The following is a description of a gene set: Human Gene Set: GSE30962_PRIMARY_VS_SECONDARY_CHRONIC_LCMV_INF_CD8_TCELL_UP species: Homo sapiens Genes up-regulated in comparison of splenic primary CD8 effector T cells at day 8 post-chronic infection versus splenic secondary CD8 effector T cells at day 8 post-chronic infection. Understanding the response of memory CD8 T cells to persistent antigen re-stimulation and the role of CD4 T cell help is critical to the design of successful vaccines for chronic diseases. However, studies comparing the protective abilities and qualities of memory and naïve cells have been mostly performed in acute infections, and little is known about their roles during chronic infections. Herein, we show that memory cells dominate over naïve cells and are protective when present in large enough numbers to quickly reduce infection. In contrast, when infection is not rapidly reduced, memory cells are quickly lost, unlike naïve cells. This loss of memory cells is due to (i) an early block in cell proliferation, (ii) selective regulation by the inhibitory receptor 2B4, and (iii) increased reliance on CD4 T cell help. These findings have important implications towards the design of T cell vaccines against chronic infections and tumors. from publication West EE, Youngblood B, Tan WG, Jin HT, Araki K, Alexe G, Konieczny BT, Calpe S, Freeman GJ, Terhorst C, Haining WN, Ahmed R (PMID 21856186), and this is the list of marker genes: NUDT21, APOOL, HMGB3, ASF1A, KIF23, MIX23, EMG1, BPHL, ENSG00000286190, UCK2, ATP5MC3, TNS1, RNF7, URB2, WEE1, ABCA3, COQ4, PRELID2, TUBGCP2, THAP12, ASS1, VPS36, RCSD1, ST6GAL1, ANKRD17, PML, AHI1 (NCBI Gene Id 54806), NUP37, RRAGA, C2orf88, SSX2IP, HAUS1, NCBP2, TUBD1, HAT1, SOWAHC (sosondowah ankyrin repeat domain family member C), BUB3, EXOSC10, PDLIM1, NUCKS1, DKK3, NETO2, WDR89, NUP93, CXCR3, P2RX7, PCNA, RBMXL1, TCF19, HOOK1, RAD51AP1, SYNPO, BRCA1, HSP90AA1 (NCBI Gene Id 89272), KPNA2, CBX2, PEX11A, HMGN3, EMB, CENPP, APOBEC2, TBC1D4, GRPEL1, IPPK, MNS1 (meiosis specific nuclear structural 1), CSTF2T, FIGNL1, NOA1, SHCBP1, CCR9, GMPS, PPRC1, THADA, ADPRH, SLAMF6, OPTN, SOSTDC1, EPCAM, IZUMO1R, HELLS, ZWILCH, DPY30, PABPC4, PRICKLE1, TCF7, NSG2 (neuronal vesicle trafficking associated 2), BCL6, PSMG1, ARMCX4, GINS1, FAM162A, EHD3, TNPO1, NOP58, PSMG2, AFF3, NXT1, MAPK8, ZNF365, BTF3, TMPO, POP5, DGKE, XRCC2, PSMD12, MBTD1, SBK1, ART3, MRPS2, STMN1, TSEN15, CLSPN, EMC8, RBBP5, MLH1, HLA-DOA, GRB7, NAA50, CXCL10, IKZF2, GDE1, CEP41, KIF22, PLEKHF2, XCL1, METTL13, FKBP5, PPP1R7, MRPS22, RPA3, PIGU, AICDA, CTPS1 (CTP synthase 1), PARD6B, PPIC, BTF3L4, TSPAN3, LYRM4, MIS18BP1, PSMD5, GTF2E2, HSH2D, TIPIN, BEX1, RTP4, UMPS, ACAD9, EIF1AX, TUBG1, ASAP1, CCR7, KTI12, AURKA, ZHX2 (zinc fingers and homeoboxes 2), FAM81A, SLC25A33, PBDC1, EIF2S3, CDK2, WWOX, PSPC1, TIMELESS, SUCLA2, SWI5, SCLT1, GNL3, IFT46, CSTPP1, PTRH1, LUZP1, FANCI, SUV39H1, AXIN2, CCDC122, NIFK, MRPL1, DSCC1, PSMA1, MBOAT1, CIP2A, MGST2, SMYD2, CCDC28B (coiled-coil domain containing 28B), PDHB, DUSP4, CD83, SCPEP1, IQCG, SNRPB2, PREP, TINF2, TNFRSF25, MAPK11 (NCBI Gene Id 5600), TFRC, CRTAM, PSMA5, TFB1M, IFT52